Given this list of marker genes SPDEF, LINC00112 (NCBI Gene Id 54089), KLHL24, C5orf47, FOXO3, EPHA6, TLR9, CEP152, HECW1, BTNL9, TAF1C, PIP, LHFPL3-AS1, KLHDC2, CSGALNACT2, MUCL3, NELL1, GUCA1B, ATP6AP1L, RNF175, HAUS3 (NCBI Gene Id 79441), FAM227B, EIF2AK3, CAMK4, CCSER1, VCPIP1, CGN, MIB2, NALF1, CPVL-AS2, TSHZ1, DRD5, FAM182A, FAAP100, GULP1, PLXDC1 (NCBI Gene Id 57125), KIAA1549, PYGO1, PTGR3, LRG1, PTPN5, FITM1, SLC22A23, TNNT2, ITM2C, COL26A1, GSTM3, INGX, NACAD, SSPN, ANGPTL3, IL37, CD177, MIDEAS, PLLP, KCND2, TMEM74, EEPD1, SCD5, PMP22, H1-3, SCLY, ITFG2, TAGLN3, SCTR (NCBI Gene Id 6344), ZNF767P, AVP, ISG20, CIRBP-AS1, OR1C1, CSMD1, TJP3, TP53TG5, CCT6B, TYR, GID4, SCOC-AS1, MRAP, ENSG00000289047, SMO, CLDN7, TUBAL3, CRMA, CBLN4 (NCBI Gene Id 140689), ABCA17P, GLYCTK, MMP15, MPZL2, POM121L8P, TMC5, EOGT, SERPINB5, INHBB, RICTOR, LYPD1, SCARA3, RASD2, MMP8, SLC30A2, CIB2 (NCBI Gene Id 404086), ARSK, LHX4, SCIN, MIER3, ZNF763, PSG5, GOLGA8IP, HSPBAP1, DNAI2, DEUP1 (deuterosome assembly protein 1), CXCL2, KIF26A, OR1I1, KCNMB2 (NCBI Gene Id 10242), JMJD8, TREML4, CCDC144A, SERTAD4-AS1, CYP2A6, CSNK1G2-AS1, NPHP3, MTHFR, MYH7B, KDM6A, ACAP2, IQCD, VSIR, LINC00582, DBP, PLXNA3, ACOXL, DOT1L, CCNG2, EVA1C, KRTAP9-8, HPSE, ACTL10, HTR1A, CYB5RL, MTCL3, MAPT (microtubule associated protein tau), LHX9, TEX19, LINC01530, ST6GALNAC5, CMTM5, SCEL, PNCK, LINC00639, KBTBD3, PAQR6, SOX3, TAF7L, PLEKHM3, SLC45A3, RNF31, PALMD, SCML1, UCKL1, CDH19, DENND4A, NCF1C, HDAC7, GALNT17, NYX, NAPSA, CBX8, SORCS1, PPFIA1, SIGLEC6, LAMA5, TECPR2, NPY4R, ERCC6L2-AS1, MSS51, LLGL2, PLAAT1, POU5F2, ANKRD34C, PCLAF, SLC25A25-AS1, ZNF510, PLEKHA1, ENSG00000271776, ADAMTS3, here is a description of the gene set: from publication Doering TA, Crawford A, Angelosanto JM, Paley MA, Ziegler CG, Wherry EJ (PMID 23159438) Genes down-regulated in CD8 T effector cells at day 15 of: acute infection with LCMV-Armstrong versus chronic infection with LCMV-Clone 13. Human Gene Set: GSE41867_LCMV_ARMSTRONG_VS_CLONE13_DAY15_EFFECTOR_CD8_TCELL_DN During acute viral infections, naïve CD8+ T cells differentiate into effector CD8+ T cells and, after viral control, into memory CD8+ T cells. Memory CD8+ T cells are highly functional, proliferate rapidly upon reinfection and persist long-term without antigen. In contrast, during chronic infections, CD8+ T cells become “exhausted” and have poor effector function, express multiple inhibitory receptors, possess low proliferative capacity, and cannot persist without antigen. To compare the development of functional memory T cells with poorly functional exhausted T cells, we generated longitudinal transcriptional profiles for each. studied in species Homo sapiens